Given this list of marker genes Sumo1, Camk2b, Ifngr2, Mapk3, Ptpn2, Socs1, Ptpn6, Ifngr1, Socs3, Ifng, here is a description of the gene set: electronically inferred by orthology from the curated human pathway Reactome Pathway: Interferon gamma signaling studied in species Mus musculus part of: Interferon Signaling This event has been computationally inferred from an event that has been demonstrated in another species.<p>The inference is based on the homology mapping from PANTHER. Briefly, reactions for which all involved PhysicalEntities (in input, output and catalyst) have a mapped orthologue/paralogue (for complexes at least 75% of components must have a mapping) are inferred to the other species.